Given this list of marker genes EPO, JAK2, EPOR, IRS2, STAT5A, LYN, STAT5B, here is a description of the gene set: part of: Signaling by Erythropoietin Reactome Pathway: Erythropoietin activates STAT5 species: Homo sapiens STAT5 (STAT5A or STAT5B) directly binds the phosphorylated cytoplasmic domain of EPOR, where it is phosphorylated by JAK2 and LYN. Phosphorylated STAT5 then dissociates from EPOR, dimerizes, and transits to the nucleus where it activates gene expression.